Given this list of marker genes TM6SF2, ZNF133, SLC5A3, SPSB1, SOX15, NDUFA3, ITFG2, XCL1, UBA52, CDKN2C, ABHD6, ACSBG2, PFDN5, C2orf68, LBP, SAP18, CD52, MCCC1, FEV, RGS5, LPP, ADAMTS5, ZMYM6, MRPL18, DYNLRB1, SLC66A1, FZD5, EPS8L3, FABP1, BMPR1B (NCBI Gene Id 658), EOLA2-DT, DOCK3, PDE8A, HOXC8, NRCAM, LMO4, LMO3, SERF2, ZKSCAN3, ZRSR2P1, BBC3, PBLD, ESRP2, SEMA6A, CLCA1, TTC1, RPL19, ING4, RABIF, LHB, RGS10, LSM1, LRRC20, ARMCX4, SELENOW, FAM111A, DARS2, NAP1L4, CSRNP2, GLRA1, LRRC75B, PPT2, RPL24, CBR1, CETP, PRSS12, ATP5F1C, MDH1 (malate dehydrogenase 1), DPF1, MRPS33, C8orf44, SIT1, PGM3, S100A10, ELOA-AS1, RPL21, PHACTR4, HAX1, ATP2B4, RPS29, RALYL, SS18L2, H4C3, CA8, POGLUT1, HPX (hemopexin), CNOT1, ARHGAP35, RPL7A, HINT1, ARFRP1, SLC35E2B, SCGB1D2, RPL15, H2AC25, MRPL17, CHD9, EBLN2, RPS15A, LAMTOR5, PIP4K2B (phosphatidylinositol-5-phosphate 4-kinase type 2 beta), MGST3, SLC66A3, IFT46, CYP2C9, TIMM8A, CD48, SDHAF1, KRT76 (keratin 76), CCT5, RUFY2, MPV17, HECTD4, SNRPD2 (small nuclear ribonucleoprotein D2 polypeptide), SPTBN4 (NCBI Gene Id 80322), TFB1M, RPL27, COQ6, IER3IP1, ATXN3L, TEP1, FMO4, RPL12, FCER1A, SPRR2B, GPR22, UQCR11, DNAJC28, RPS10, EIF3K, EIF2S2 (eukaryotic translation initiation factor 2 subunit beta), RABEPK, PYY2, GSTO1, POU3F1, RUFY3, CCDC51, TIMM8B, SNRPC, YY2, SLITRK5 (NCBI Gene Id 26050), RPL5, GPR171, C11orf16, GUCY1A1, MAGEC3, COL6A1, POLR2J, COX4I1, BOLA1 (NCBI Gene Id 51027), RPS13, RPS16, MYL7, GTF2H2B, RPA3, SYNRG, SOD3, OXA1L, C21orf91, ZNF613, INO80B (NCBI Gene Id 83444), HPCA, LIPE, TARP, PPP2R5B, ADGRA2, EEF1B2, FHOD3, MYL10, SLC16A4 (solute carrier family 16 member 4), SEMA6C, RPL10A, TERF2 (NCBI Gene Id 7014), YIPF6, COMMD3, PNPLA4, DZANK1, FOXA2, TGFB3, GRIA1, VPS37A, HMGCL, EPOR, TNPO3, CDX2, LIF, COA4, RNF113A, ATAT1, TAOK2 (NCBI Gene Id 9344), PHF11, CFAP43, DYNLL1, FOXO4, CD53, here is a description of the gene set: Objective: We hypothesized that type 1 diabetes (T1D) is accompanied by changes in gene expression in peripheral blood mononuclear cells (PBMCs) due to dysregulation of adaptive and innate immunity, counterregulatory responses to immune dysregulation, insulin deficiency and hyperglycemia. Research Design and Methods: Microarray analysis was performed on PBMCs from 43 patients with newly diagnosed T1D, 12 patients with newly diagnosed type 2 diabetes (T2D) and 24 healthy controls. One and four month follow-up samples were obtained from 20 of the T1D patients. Results: Microarray analysis identified genes differing in expression between newlydiagnosed T1D patients and controls at a false discovery rate of 0.05. Changes in expression of interleukin-1β (IL1B), early growth response gene 3 (EGR3), and prostaglandin-endoperoxide synthase 2 (PTGS2) resolved within four months of insulin therapy and were also observed in T2D suggesting that they resulted from hyperglycemia. With use of a knowledge base, 81/genes could be placed within a network of interrelated genes with predicted functions including apoptosis and cell proliferation. IL1B and the MYC oncogene were the most highly-connected genes in the network. IL1B was highly overexpressed in both T1D and T2D, whereas MYC was dysregulated only in T1D. Conclusion: T1D and T2D likely share a final common pathway for beta cell dysfunction that includes secretion of interleukin-1β and prostaglandins by immune effector cells, exacerbating existing beta cell dysfunction, and causing further hyperglycemia. The results identify several targets for disease-modifying therapy of diabetes and potential biomarkers for monitoring treatment efficacy. Human Gene Set: GSE9006_TYPE_1_DIABETES_AT_DX_VS_4MONTH_POST_DX_PBMC_DN Genes down-regulated in comparison of peripheral blood mononuclear cells (PBMC) from patients with type 1 diabetes at the time of the diagnosis versus those at 4 months later. from publication Kaizer EC, Glaser CL, Chaussabel D, Banchereau J, Pascual V, White PC (PMID 17595242) species: Homo sapiens